The following is a description of a gene set: species: Mus musculus The process by which a virion protein binds to molecules on the host cellular surface or host cell surface projection. Mouse Gene Set: GOBP_VIRION_ATTACHMENT_TO_HOST_CELL, and this is the list of marker genes: Ace2, Icam1, Nectin2, Lrrc15, Gas6, Hsp90ab1